Given this list of marker genes Aco1, Acly, Cs, Aco2, Csl, here is a description of the gene set: Mouse Gene Set: GOBP_CITRATE_METABOLIC_PROCESS The chemical reactions and pathways involving citrate, 2-hydroxy-1,2,3-propanetricarboyxlate. Citrate is widely distributed in nature and is an important intermediate in the TCA cycle and the glyoxylate cycle. studied in species Mus musculus